The following is a description of a gene set: Human Gene Set: HP_ABNORMAL_PELVIS_BONE_OSSIFICATION Abnormal pelvis bone ossification species: Homo sapiens An abnormality of the formation and mineralization of any bone of the bony pelvis., and this is the list of marker genes: IFT80, CBFB, COL2A1, WDR35, GSC, GJB2, FIG4, DYNC2I1, DYNC2I2, LBR, RUNX2, LEMD3, NKX3-2, FGFR2, GJB6, SIK3, DYNC2H1